Given this list of marker genes Shisa7, Cnih2, Shisa9, Neto1, Homer1, Crhbp, Cacng4 (NCBI Gene Id 54377), Mink1, Lrp8, Cacng8, Begain, Shisa6, Chrna5, Rasgrf1, Nlgn3, Homer3, Oprm1, Notch1, Cacng3, Slurp2 (secreted Ly6/Plaur domain containing 2), Adrb2, Psca, Lynx1, Dapk1, Cacng5, Mapk8ip2, Nrxn2, Shank1, Pate4, Prrt1, Gsg1l, Cnih3, Rasgrf2, Reln, Nlgn1, Cacng2, Nlgn2, Crh, Cacng7, Dlgap2, here is a description of the gene set: species: Mus musculus Any process that modulates the frequency, rate or extent of neurotransmitter receptor activity. Modulation may be via an effect on ligand affinity, or effector function such as ion selectivity or pore opening/closing in ionotropic receptors. Mouse Gene Set: GOBP_REGULATION_OF_NEUROTRANSMITTER_RECEPTOR_ACTIVITY